The following is a description of a gene set: Genes containing one or more binding sites for (RPA1) in their promoter regions (TSS -1000,+100 bp) as identified by GTRD version 20.06 ChIP-seq harmonization. from publication Yevshin I, Sharipov R, Kolmykov S, Kondrakhin Y, Kolpakov F (PMID 30445619) Human Gene Set: RPA1_TARGET_GENES species: Homo sapiens, and this is the list of marker genes: POLR3E, AGBL5-AS1, METTL26, MIR7-3HG, HTR5A, RNVU1-15, MT-TT, DNAJC16, ABR, LRP3, VTRNA1-1 (NCBI Gene Id 56664), MT-TF, ZNF581, TOMM40, VTRNA1-2, RSU1, MT-ND4, SEZ6, MT-ND1, LINC00431, SCRT1, MT-TE, KPNA7, PPP6R3, SNAP25-AS1, NCOA7, PRRG2, AGBL5, YJU2B, WDR1, AFAP1, SACM1L, MT-TN, MTND5P11, ZNF580, TGFB1, MT-RNR2, MT-ND6, MT-ND3, TMEM102, MT-TD, MCRIP2, MT-TL1, AARSD1, PDCD6 (NCBI Gene Id 206269), ITGA3, HSPA6, VTRNA1-3, MT-CYB, MT-RNR1, PDCD6-DT, TMEM91 (NCBI Gene Id 641649), MT-TA, MT-TV, MT-TC, SLC11A2, MTCO3P12, SF1 (NCBI Gene Id 7536), MT-TP, NOSIP, CSNK1G3, ZNF574, YIPF2, MT-TY, GTPBP1, P2RX6 (NCBI Gene Id 9127), MT-ND4L, CASP9, SF1-DT, BRF2, MIR7-3, LIMD1-AS1, MT-TR, GRN, B4GAT1, RPA1, TIMM29, EEF1A1